Given this list of marker genes Sin3a, Hint1, Lef1, Ctnnb1, Myrip, Usf1, Hdac1, Tcf7l1, Mapk14, Mitf, Mlph, Tcf7l2, Rab27a, Tcf7, Myo5a, Sytl2, here is a description of the gene set: MITF-M-dependent gene expression Mouse Gene Set: REACTOME_MITF_M_DEPENDENT_GENE_EXPRESSION studied in species Mus musculus